Given this list of marker genes DVL3, DVL1, ASXL1, WNT5A, DIS3L2, FZD2, PUF60, here is a description of the gene set: Human Gene Set: HP_NAEVUS_FLAMMEUS_OF_THE_EYELID Naevus flammeus localized in the skin of the eyelid. studied in species Homo sapiens Naevus flammeus of the eyelid